The following is a description of a gene set: The presence of axonal regeneration following a previous axonal lesion. Axonal regeneration studied in species Homo sapiens Human Gene Set: HP_AXONAL_REGENERATION, and this is the list of marker genes: NEFL, LMNA, GNB4, GDAP1 (ganglioside induced differentiation associated protein 1), HK1, YARS1, JPH1